The following is a description of a gene set: Progressive macrocephaly species: Homo sapiens Human Gene Set: HP_PROGRESSIVE_MACROCEPHALY The progressive development of an abnormally large skull., and this is the list of marker genes: GCDH, NDUFS4, PIK3CA, HEXB, PTEN, AKT1, GFAP